The following is a description of a gene set: A kind of short stature in which different regions of the body are shortened to differing extents. Disproportionate short stature species: Homo sapiens Human Gene Set: HP_DISPROPORTIONATE_SHORT_STATURE, and this is the list of marker genes: BRF1, CFAP410, DVL1, SIK3, MATN3, TONSL, TRAPPC2, RAB33B, SHOX, WNT5A, WDR19, PKDCC, FLNB, MESP2, RNU4ATAC, MMP13, CLPB, KYNU, COL2A1 (NCBI Gene Id 444981), CEP57, INPPL1, COL10A1, B3GLCT, RMRP, ACP5, CRTAP, DHCR7, NKX3-2, ALPL, PTH1R, BMPR1B, FGFR2, CHST3, PHEX, RSPRY1, WDR35, TBX15, B3GAT3, NXN, CTSK, ACAN, CCN6, TBK1, IFT140, EVC2, HDAC6, PUF60, ARSK, MTOR, XYLT1, KIAA0753 (NCBI Gene Id 9851), CANT1, ARCN1, POC1A, SLC39A8, GPX4, GPC6, CCN2, PCYT1A, EBP, GLI1, IFT122, TRIP11, SLC26A2, COG1, LBR, COL1A1, CSPP1, SLC35D1, PRKACB, KMT2A, ARSB, DDRGK1, KIF22, GSC, DYNC2LI1, KDELR2, GALNS, PRKACA (protein kinase cAMP-activated catalytic subunit alpha), HS2ST1, MESD, PRKG2, DYM, IFT52, PCNT, FGFR1, NPR2, PPIB, EVC, KIAA0586, FN1, DDR2, FGFR3, IFT43, BMPER, TRPV4, AGPS, XYLT2, PEX7, IHH, WNT7A, XRCC4, CSGALNACT1 (chondroitin sulfate N-acetylgalactosaminyltransferase 1), COL11A2, SOX9, P3H1, DHCR24, SERPINH1, SLC10A7, CEP120, MAB21L2, ALG9, NSMCE2, MYSM1, C1GALT1C1, CREB3L1, MIR140, DYNC2I2, ALG12, COMP, EXTL3, SMARCAL1, TBX6 (NCBI Gene Id 6911), ROR2, GDF5, PRKAR1A, IFT80, FZD2, BGN, HSPG2, GNPNAT1, DYNC2I1, DYNC2H1, COL1A2, MBTPS2, COL11A1, DLL3, ASXL1 (NCBI Gene Id 23393), GNPAT, GLB1